Given this list of marker genes YTHDF2, EPDR1, SMIM13, PAFAH1B2, POSTN, TMEM74, ZNF28, QKI, GABARAPL1, HACE1, USP44, DENND11, OR51E1, EMP1, PHC3, NUP50, TMEM135, ATAT1, EPHX2, SELENOS, CTTNBP2NL, TNFRSF11B, CLPX, EGLN3, ZC3H8, TSHZ2, TSPAN2, RORA, CCZ1, ADAMTSL3, TMBIM4, ANK3, NBEA, ZNF251, COL4A4, PRKCE, ZNF461, YOD1, ZNF713, YPEL5, EMC2, TBC1D12 (TBC1 domain family member 12), CRPPA, RFX7, CPEB2, DDAH1, MYCN, SLC44A1, ANP32E, TTC22, CCZ1B, PTPDC1, ZNF860, LYRM4, CFAP251, PFKP, HMGB1, RAB39A, UTY, RNF111 (NCBI Gene Id 54778), GJA1, PAK2, NR2F2, PPP3CA (protein phosphatase 3 catalytic subunit alpha), TRPV3, TSPAN7, SNIP1, NAMPT, PHACTR2, GPATCH1, HCN1, ZNF845, NIPAL1, RSBN1, UNC5D, MTMR6, ASXL3, DNAJB14, BRWD3, GBP4, PRDM1, TRPC1, TPM3, MAN1A2 (NCBI Gene Id 10905), HS6ST3, SERPINB10, KPNA7, MAP4K4, PICALM, ZNF22, ALDH7A1, KCTD3 (potassium channel tetramerization domain containing 3), GBP1, KBTBD2, BCO1, BTLA, VNN2, HECA, C8orf34, FBXO9, LMAN1, ATOSA, MCM10, ELAVL4, TARDBP, IBSP, SFSWAP, POLR3F, ASPH, PYURF, PTEN, SREK1, MRPL44, ZBTB11, TMEM38B, CDK17, TXK, GAB2, KIDINS220, SKIL, TMTC1, FMR1, DR1, MAGI3, DNAAF4, BEND4, ARMC1, WNT5B (Wnt family member 5B), PRMT9, CCNG2, ERBB4, RTKN2, PDGFC, BIRC3, NCOA4, CISH, AKAP11, BEND2, TRIM5, MINDY2, TIMM23B, ZNF761, QRICH1, PIGY, BBS7, INPP5A, KATNAL1, IFT56, NHS, ANKRD29 (ankyrin repeat domain 29), ZFTA, ATAD2B, PTPRE, ENDOD1, GALNT7, CHEK1, RBM46, SEMA5A, API5, WNK3, here is a description of the gene set: Genes predicted to be targets of miRBase v22 microRNA hsa-miR-513b-3p in miRDB v6.0 with MirTarget v4 prediction scores > 80 (high confidence targets). studied in species Homo sapiens Human Gene Set: MIR513B_3P from publication Chen Y, Wang X (PMID 31504780)